Given this list of marker genes HSPA8P11, RPL10P18, ENSG00000288964, LINC02099, RPL23P10, DUSP26, RN7SL457P, HIKESHIP3, ENSG00000253452, RPL6P22, LINC02948, ENSG00000305122, RNU6-528P, MTCYBP19, WRN, LSM12P1 (LSM12 pseudogene 1), RN7SL621P (RNA, 7SL, cytoplasmic 621, pseudogene), NRG1, UNC5D, RNU6-1218P, PPIAP84, RNU5A-3P, MTND2P32, SNORA70, RNU6-533P, DUSP4, RPL21P80, RANP9, DCTN6-DT (NCBI Gene Id 118597835), RNF122, RPL17P33, VENTXP5, RNA5SP263, SNORD13, MAK16, SARAF, LINC00589, MTND5P41, ENSG00000253632, KIF13B, UBXN8, RNA5SP262, MTND1P6, PPP2CB, KCTD9P6, RNA5SP260, FUT10, BUD31P1, ENSG00000248964, TTI2, MAP2K1P1, RNA5SP261, HMGB1P23, RBPMS-AS1, RPS15AP24, DCTN6, MIR3148, MTND6P19, TUBBP1, PURG, GTF2E2, LEPROTL1, RPL10AP3, GSR, LINC02209, SMIM18, MBOAT4, NRG1-IT3, NRG1-IT1, RNU6-663P, TEX15, SUMO2P16, RBPMS, LINC01288, ENSG00000309816, ENSG00000305693, ENSG00000286131, here is a description of the gene set: Human Gene Set: chr8p12 studied in species Homo sapiens